Given this list of marker genes Irx1, Irx2, Osr1, Hes5, Irx3, here is a description of the gene set: studied in species Mus musculus The regionalization process in which specific areas of cell differentiation are determined along a proximal/distal axis of a nephron. The proximal/distal axis is defined by a line that runs from the center of the kidney (proximal end) outward (distal end). Mouse Gene Set: GOBP_PROXIMAL_DISTAL_PATTERN_FORMATION_INVOLVED_IN_NEPHRON_DEVELOPMENT